The following is a description of a gene set: Cytokines mediate cell-cell communication in the immune system and represent important therapeutic targets. A myriad of studies have highlighted their central role in immune function, yet we lack a global view of the cellular responses of each immune cell type to each cytokine. To address this gap, the authors created the Immune Dictionary, a compendium of single-cell transcriptomic profiles of more than 17 immune cell types in response to each of 86 cytokines (>1,400 cytokine-cell type combinations) in mouse lymph nodes in vivo. A cytokine-centric view of the dictionary revealed that most cytokines induce highly cell-type-specific responses. For example, the inflammatory cytokine interleukin-1β induces distinct gene programmes in almost every cell type. A cell-type-centric view of the dictionary identified more than 66 cytokine-driven cellular polarization states across immune cell types, including previously uncharacterized states such as an interleukin-18-induced polyfunctional natural killer cell state. Mouse Gene Set: CUI_B_CELL_IL36RA_RESPONSE_UP from publication Cui A, Huang T, Li S, Ma A, Pérez JL, Sander C, Keskin DB, Wu CJ, Fraenkel E, Hacohen N (PMID 38057668) Genes positively differentially expressed in cell type: B cell upon treatment with cytokine: IL-36Ra in mouse lymph nodes in vivo. species: Mus musculus, and this is the list of marker genes: Ly6a, H2-T22, H2-Q6, Psmb9, Ms4a4c, Xaf1, Irf7, Plac8, Atraid